Given this list of marker genes Vps33b, Prkcq, Ptprj, Selp, Fundc2, Tmx1, Hrg, Mfsd2b, Syk, Svep1, Pdpn, Prkcd, Sh2b3, Htr2a, Gp9, Adamts18, Plek, Gp1bb, Gp5, Mmrn1, Prkca, Fcer1g, Il6ra, C1qtnf1, Cd9, Prkg1, Jak2, Gp1ba, Flna, F11r, Cela2a, Ctsg, Apoe, Serpine2, Ceacam1, Emilin1, Tec, Pdgfb, Il6, Tlr4, Lyn, Ubash3b, Gnaq, Pla2g4a, Pdgfa, Alox12, Emilin2, Pear1, Pdgfra, here is a description of the gene set: Mouse Gene Set: GOBP_REGULATION_OF_PLATELET_ACTIVATION Any process that modulates the rate or frequency of platelet activation. Platelet activation is a series of progressive, overlapping events triggered by exposure of the platelets to subendothelial tissue. species: Mus musculus